Given this list of marker genes TUG1, ACSS1, SLC35A3, FAM204A, DDB2, HABP4, PAFAH1B1, IPP (NCBI Gene Id 3652), JTB, ZNF251, MRPL16, ZFX, RSRP1, MED20 (NCBI Gene Id 9477), RPL5, TMEM167A, ANXA9, CSTF2, SLC30A7, CREB1 (cAMP responsive element binding protein 1), ABCB1, ECHDC2, UBR3, DNAI4, ZNF408, ZNF623 (NCBI Gene Id 9831), SCAF4, BMS1, DGCR8, RAB14 (RAB14, member RAS oncogene family), ANKLE1, NAA38, CA5B (carbonic anhydrase 5B), CSNK1E, BTBD9, PCK2, PARP11, STK38, CNOT6, PDPR, BCDIN3D, FAF2, PTPN21, HLTF (NCBI Gene Id 6596), BRWD1, HHAT, CYB5A, FEZ2, SFT2D2, ZFC3H1, RBM27, ITGAL, SLC25A35, NAP1L4, RAB6B, ATP2A3 (ATPase sarcoplasmic/endoplasmic reticulum Ca2+ transporting 3), PAG1, SEPTIN6, MICAL1, BDP1 (NCBI Gene Id 59278), INAFM1, EPC1, NUFIP2, TOLLIP, ZFYVE1, CHRNB1, RIOX2, ZNF318, CYTH2, LRRC8C, NECAP1, RBAK, RBM33, USP47, CYB5R4, SLC43A2, OSTM1, GAA, FKTN, CARD6, SPN, TENT5A, ZNF12, PGAP6, SAMHD1, FEM1C, STK24, NCKAP1L, RPL27, GRINA, PHC3, APPL1, HP1BP3, STK25, HGSNAT, CGGBP1, NUP58 (nucleoporin 58), UIMC1, POLK, SEC24C, TMEM229B, INPPL1, VAMP4, CELF1, DCP1A, IKBKB, CAMKK2 (calcium/calmodulin dependent protein kinase kinase 2), ACSF3, KPNA1, DCUN1D4, SOWAHA, SYNRG, TASL (NCBI Gene Id 80231), ZXDB, BCL10, NFATC2IP, GIMAP4, CEPT1 (choline/ethanolamine phosphotransferase 1), ARHGAP30, NABP1, MOSMO, WNK1, CD200R1L, RAPGEF2, RBM15B, BLTP3B, RORA, TRIM25, EXOSC8, TFB2M, CLINT1, NUMB, ZNF563, ANKH, ANKRD44, MSN, QPRT, SIDT2, DOCK11, TRAPPC10, KIAA1191, PNPLA7, HINFP, ARHGEF39, TEX14 (testis expressed 14, intercellular bridge forming factor), RETREG3, RBSN, NIPAL3, BTAF1 (NCBI Gene Id 9044), ARMC5, ZDHHC7, PARP14, PSMB9, MAN2A2, CBX7, PHF3, OGT, MRPS2, PPP1R15B, C2orf68, TOR1AIP1, ATP11B, FAM8A1, TIGAR, SFXN3, PLA2G15, PFKFB4, DIPK1A, IL9R, TMEM81, HEXA, TM9SF2, CCNT2, RASSF6, FAM117B, PHYKPL, DOCK10, PTGR3, EPM2AIP1, BTRC, ALG5, TM9SF3, WDR48, TBL2, CERT1, MORC3, RNF185, FKBP1A, RBM41, SHPRH, NRBF2, PEAK1, MAPK11, TMEM129, ARHGAP25, ASB1, PRDM9, NDUFB3, NRF1, here is a description of the gene set: from publication Williams MA, Ravkov EV, Bevan MJ (PMID 18356084) Genes up-regulated in comparison of CD4 T cells from mice challenged with LCMV versus those challenged with Listeria-gp61. studied in species Homo sapiens Following infection with LCMV, CD4+ SMARTA TCR transgenic cells (specific for the gp61-80 epitope of the LCMV glycoprotein) rapidly expand, become effector cells, and go on to form a long-lived memory population. Following infection with a recombinant Listeria monocytogenes expressing the LCMV epitope gp61-80, SMARTA cells also expand but display defective effector differentiation and fail to form memory. In an attempt to understand the signals required for CD4 T cell memory differentiation, we compared gene expression by SMARTA cells at the peak of the primary response following either Lm-gp61 or LCMV infection. Human Gene Set: GSE10094_LCMV_VS_LISTERIA_IND_EFF_CD4_TCELL_UP